Given this list of marker genes CLEC4E, PPP4R1 (protein phosphatase 4 regulatory subunit 1), CATSPERG, ZYX, GPR87, SLC6A6, ZCCHC4, FZD9, MKNK1, FCF1, YIPF1, NLGN1, PPIF, REL, NQO2, HIPK1, JADE1, PF4V1, MTSS2, NTSR2, SDHB, PI3, PLXNC1, CASZ1, FOSL1, BASP1, OR11A1, SPA17, IFNA2, MKRN1, LPAR2, MSL1, CUEDC1, TNFRSF25, TAP2, STC1, HLA-A (major histocompatibility complex, class I, A), BEX1, CATSPERZ, CYP4F2 (cytochrome P450 family 4 subfamily F member 2), IFIT2, TMEM59, RNF19B, CDC42EP2, DTX2, HBE1, TBX3, ERO1A, ABCC5, CXCL6, GSK3B, C2, NIBAN1, TSSK2, SMCP, FAM110B, ZFR2, SH2D1A, CREB5, CLEC4A, ULBP1, ST3GAL6, KDM5A, ARPC5, RAB5IF, CYP46A1, SIGLEC5, SST, C1RL, HK3, MMP25, JPT1, PLN, MFAP3L, SMARCD3, FRAT2, CHRDL1, BCL3, LPIN2, LOXL1, PSTPIP2, HK2, CEACAM6, LILRA3, HYAL1, NECTIN3, CST7, MYL12B, XPO6, GABRA3 (NCBI Gene Id 2556), ATP12A, TRPV4, GRIA2, RAB36, TRIM25, DDX21, IP6K1, LIMK2, TBC1D2B, LGI2, SATB1, PFKFB3, FAM53C, NXF2, CHST15, BHLHE40, MAP1LC3B, SLC34A2, PGGHG, GALNS, FOSL2, BLVRA, LUZP4, CYTH4 (NCBI Gene Id 29776), KCNQ1DN, CX3CL1, UNC5B, PSG4, SHC3, RALB, TNFSF8, CST1, CSTA, NMUR1, CCNJL, OTULINL, PPP2R5A, GRIK3, SECTM1, ADIPOR1, ABHD2, DCBLD2, HEXB, HOXA5, VNN1, P2RX1, MYO9B, IFT56, RIPPLY3, PRKCQ, ETS2, SELPLG (selectin P ligand), CYTIP, IFITM1, SPIN2A, RGS14, FBXO24, LRRFIP1, TMUB2, PZP, PITX1, PSG11, SERPING1, IMPA2 (NCBI Gene Id 3613), KRT23, GMIP, BRAP, DCAF11 (NCBI Gene Id 80344), KRT1, TCIRG1, ZNF674, SGK2, VPS37A, KRT32, GK, RUNDC3A, RAG2, NUMB, BPGM, ING3, SIGLEC7 (sialic acid binding Ig like lectin 7), MBP, NEDD9, MON1B, NRDC, AKR1C4, ANXA3, F9, SERINC3, ICAM1, RAB7A, NDRG1, PSG9, MAB21L2, EFHD2, SERPINC1, ATP6V1B2, MKLN1, SNORA21, SLC22A4, F13A1, GPR27, F2RL1, PXN, FGR, PITPNM1, PLAU, ACTR3, ZBTB43, IMPDH1, here is a description of the gene set: In the present study we used Affymetrix oligonucleotide microarrays to produce gene transcription profiles for the major leukocyte types in humans. This comprehensive dataset enabled us to not only establish which genes were expressed in each leukocyte type, but also which genes were expressed in each subset after activation. The used of a comprehensive dataset of gene profiles from all the major human leukocyte subsets enabled a novel and powerful means for identification of genes associated with single leukocyte subsets, or different immune paradigms. Human Gene Set: GSE3982_NEUTROPHIL_VS_BCELL_UP Genes up-regulated in comparison of neutrophils versus B cells. studied in species Homo sapiens from publication Jeffrey KL, Brummer T, Rolph MS, Liu SM, Callejas NA, Grumont RJ, Gillieron C, Mackay F, Grey S, Camps M, Rommel C, Gerondakis SD, Mackay CR (PMID 16474395)